The following is a description of a gene set: species: Mus musculus Genes negatively differentially expressed in cell type: Macrophage upon treatment with cytokine: IFN-γ in mouse lymph nodes in vivo. Cytokines mediate cell-cell communication in the immune system and represent important therapeutic targets. A myriad of studies have highlighted their central role in immune function, yet we lack a global view of the cellular responses of each immune cell type to each cytokine. To address this gap, the authors created the Immune Dictionary, a compendium of single-cell transcriptomic profiles of more than 17 immune cell types in response to each of 86 cytokines (>1,400 cytokine-cell type combinations) in mouse lymph nodes in vivo. A cytokine-centric view of the dictionary revealed that most cytokines induce highly cell-type-specific responses. For example, the inflammatory cytokine interleukin-1β induces distinct gene programmes in almost every cell type. A cell-type-centric view of the dictionary identified more than 66 cytokine-driven cellular polarization states across immune cell types, including previously uncharacterized states such as an interleukin-18-induced polyfunctional natural killer cell state. from publication Cui A, Huang T, Li S, Ma A, Pérez JL, Sander C, Keskin DB, Wu CJ, Fraenkel E, Hacohen N (PMID 38057668) Mouse Gene Set: CUI_MACROPHAGE_IFNG_RESPONSE_DN, and this is the list of marker genes: Gdi2, Cox7a2l, Kctd12, Sh3pxd2a, Avpi1, Npm1, Stk17b, Cd33, Gpi1, Tbc1d4, Ptpn18, Sec14l1, Tep1, Ftl1, Rsrp1, Lamp1, Hscb, Gna12, Hmox1, Atp13a2, Mknk2, Slc43a2, Sgk1, Ppfia4, Syk, Idh1, Ifngr1, Grap, Mafb, Dusp1, Gpr137b, Apoe, Nfkbia, Rgs10 (regulator of G-protein signalling 10), Top2b, Comt, Gsto1, Cdc40, Arhgef6, Apip, Prxl2b, Haus8, Ncoa4, Etv5, Eif4b, Rxra, Rxrg, Uchl3, Syndig1l, Frmd4b, Spic, Snx18, Nherf2, Nostrin